The following is a description of a gene set: species: Homo sapiens Discrimination between self vs. non-self and adequate response to infection and tissue damage are fundamental functions of the immune system. The rapid and global spread of known and emerging viruses is a testament that the timely detection of viral pathogens that reproduce within host cells, presents a formidable challenge to the immune system. To gain access to a proper reproductive niche, many pathogens travel via the host vasculature and therefore become exposed to humoral factors of the innate immune system. Although a cascade of coagulation factors plays a fundamental role in host defense for “living fossils” such as horseshoe crabs (Xiphosurida spp), the role of the coagulation system in activation of innate responses to pathogens in higher organisms remains unclear. When human type C adenovirus (HAdv) enters the circulation, 240 copies of coagulation factor X (FX) bind to the virus particle with picomolar affinity. Here, using molecular dynamics flexible fitting (MDFF) and high resolution cryo-electron microscopy (cryo-EM), we defined the interface between the HAdv5 hexon protein and FX at pseudo-atomic level. Based on this structural data, we introduced a single amino acid substitution, T424A, in the hexon that completely abrogated FX interaction with the virus. In vivo genome-wide transcriptional profiling revealed that FX-binding-ablated virus failed to activate a distinct network of the early response genes, whose expression depends on transcription factor NFKB1. Deconvolution of the signaling network responsible for early gene activation showed that the FX-HAdv complex triggers MyD88/TRIF/TRAF6 signaling upon activation of toll-like receptor 4 (TLR4) that serves as a principal sensor of FX-virus complex in vivo. Our study implicates host factor “decoration” of the virus as a mechanism to trigger innate immune sensor that respond to a misplacement of coagulation FX from the blood into intracellular macrophage compartments upon virus entry into the cell. Our results further the mounting evidence of evolutionary conservation between the coagulation system and innate immunity. Human Gene Set: GSE36078_UNTREATED_VS_AD5_INF_IL1R_KO_MOUSE_LUNG_DC_DN from publication Doronin K, Flatt JW, Di Paolo NC, Khare R, Kalyuzhniy O, Acchione M, Sumida JP, Ohto U, Shimizu T, Akashi-Takamura S, Miyake K, MacDonald JW, Bammler TK, Beyer RP, Farin FM, Stewart PL, Shayakhmetov DM (PMID 23019612) Genes down-regulated in Lung dendritic cell from untreated IL-1R mice versus Lung dendritic cell from Ad5 inf IL-1R mice., and this is the list of marker genes: PYCARD, RTL5 (retrotransposon Gag like 5), F2R, EML3, PLSCR3 (NCBI Gene Id 57048), ZDHHC15, SMAGP, CCR1, RAB11FIP4, MAML2, FOXC1, ADAM7 (NCBI Gene Id 8756), ZNF335, OTOR (otoraplin), MUC1, BRPF3, FOXM1, TRIOBP, SPNS1, MINK1, HYLS1, ABHD10, TTLL12, PPP1R1C, SEC24C, IFNGR1, UNC13B, ZDHHC21, RGS18, PTCHD3, FAM229B, AIMP2, CCT8L2, PSMC3, NBEA, DAB2IP, DIMT1, MBD6, PTGR1, RFXAP, DCAF6, COL27A1, KAT8, MAN1B1, NAT10, SRL, NEDD4, BAK1 (BCL2 antagonist/killer 1), PCDHB11, ITIH5 (inter-alpha-trypsin inhibitor heavy chain 5), SMG8 (SMG8 nonsense mediated mRNA decay factor), GABRA4, C14orf28, C11orf87 (chromosome 11 open reading frame 87), DCAF12, ATP6V1E1, HDAC4, N4BP2L2, VXN, GALNT14, STIP1, MYBL2, NMT1, HJV (hemojuvelin BMP co-receptor), ALOX15, FTMT, CAPNS1, THAP12, TAAR1, HASPIN, DNAAF2, CYP3A43, MMP16, LYSMD3, BCL2L1, ZNF703, RAD50, GDAP2, BIRC5, PPT1, PRKAR2B, MXRA8, PCDHB14, ZBP1, G6PC1, TRPC4AP, RAD51B, ZBED6, VIL1, NWD2, COPS2, FBLN5, IL15, MARK1, ZNF454, RAP1GAP2, HBG2, AGO3, GLTP, LNX1, PCYT1A, PRR22 (NCBI Gene Id 163154), ENPP1, FGD4, CKAP2, SH3GL1, BMX, WIF1, PHC3, MORC2, ANXA2, GNA11, IL18RAP, UPK1A, EME1, THSD4, AVEN (apoptosis and caspase activation inhibitor), CTDSPL, SLC30A7, ZBTB14, CYTH2, C15orf39 (chromosome 15 open reading frame 39), ALPI, PCDHB16, MIXL1 (Mix paired-like homeobox), PLAU, GPR160, CTSD, SOWAHC, FRMD3, ZDHHC4, CCNK, CHD7, PPP1R18, TPM3, MED23, NUDT4, CDCA2, AARD, UBE2C, PCDH20, RTBDN, SOCS2, NKG7 (NCBI Gene Id 4818), LSM6, TSPAN2, N4BP1, LSM12, CA5B, PTGFRN, HEXIM2, TGM2, GLIPR1, CBX4, CPA6, ATRAID, COMMD4, MCF2, CUZD1, TRIM65, CDK8, OGDH, CTDNEP1, KY, RNF126, LDLRAD3, TMEM170A, SPAG6, HS6ST1, CCNF, GMNN, KCNK5, NME5, PEX14, IL10RA, AMOTL1, TTLL3, EPHB1, DGKH, ZNF697, RMDN2 (regulator of microtubule dynamics 2), COPE, ZNF566, LDAF1, DNAH7, AGK, CACNB2, CAPN8, TGFB3, FAM217B, NEU2, SMC1B, WASHC5, RAB9B, NOD1, EIF3C, PLEKHO1, PFKFB4, CD37, CD68